Given this list of marker genes ELN, ROCK1, TMOD3, OAZ3, ARF6, WASF1, NCK1, SPTBN2, PIK3R2, CD47, PPM1F, RHOC, FERMT2, ABITRAM, CLASP1, GMFG, EVL, WASHC1, XIRP2, CSF3, PPM1E, SPTAN1, DSTN, MTSS1, RHPN2P1, ASAP3, CYRIB, PFN1, ITGB1BP1, CYFIP2, DNAI3, CCR7, KIRREL1, AVIL, ROCK2, TTC8, LMOD3, SWAP70, BAG4, WASF3, SLIT2, MAGEL2, RHPN2, S100A10, CARMIL2, INPP5K, CDC42EP3, C9orf72, ARHGEF18, CAPZA3, ARHGEF10L, PHLDB2, TESK1, NCKAP1, SHANK1, ARHGAP35, SPTA1, HAX1, LIMK1, ARHGEF5, PFN2, CORO1B, LMOD2, PAK3, PTGER4, RGCC, DLG1 (discs large MAGUK scaffold protein 1), TAC1, MLST8, TRIM27, WASF2, SVIL, PYCARD, PLEKHH2, PRKN, RASA1, CDC42, ALMS1, ADD2, NF2, FLII, PIK3R1, SERPINF2, VASP, BRAF, DMTN, GMFB, CARMIL3, SEMA5A, CCL24, MTPN, NAA80, CCL11, PICK1, BBS4, CFL1, SNX9, WASHC2A, CDC42EP2, TGFB3, CORO2B, WASH6P, CRACD, GSN, NPHS1, BAIAP2, WASHC3, FLNA, KANK2, F2RL1, CTTN, ADD1, MIR20A, TMOD1, TWF2 (NCBI Gene Id 11344), AP1AR, HCK, TACSTD2, WASHC2C, CAPZB, MTOR (NCBI Gene Id 2476), CTNNA2, SMAD3, VIL1, INPPL1, SPTBN5, SH3BP1, MKKS, RGS4, MET, SYNPO (synaptopodin), BAIAP2L2, TWF1, TPM1 (NCBI Gene Id 7168), SSH2, TMOD2, PAK2, ABI2, CCL26, CYRIA, ARHGEF10, ASB2, CLASP2, PDXP, BIN1, AMOT, CCL21, ALOX15, MIR21, HIP1R, KANK3 (KN motif and ankyrin repeat domains 3), FCHSD1, TMSB4X, ARPC5L (actin related protein 2/3 complex subunit 5 like), ACTN2, WAS, FER, ESAM, CFL2, ARPC3, CCDC88A, F11R, SLC9A1, LATS1, CGNL1, ARHGAP6, STMN1, LMOD1, SPTBN1, GPR65, CYFIP1, FHOD1, SCIN, CARMIL1, COTL1, WDR1, ACTG1, SSH1, ARHGEF15, LIMCH1, NRP1, SSH3, ARFGEF1, NCKAP1L, KANK1, SORBS3, WASHC4, SPECC1L, ARAP1, ARF1, VILL, TGFBR1 (transforming growth factor beta receptor 1), TENM1, SYNPO2, RICTOR, EPHA1, PXN, RNH1, TMEFF2, SHANK3, MIR149, MYOC, PREX1, NCK2, CDC42EP4, RAPGEF3, TSC1, RDX, MIR214 (NCBI Gene Id 406996), FRMD7, FCHSD2, CAPZA1, SPTB, LIMA1, APOA1, WNT4 (Wnt family member 4), ARFIP2, CXCL12, TACR1, RAC1, WHAMM, SFRP1, KANK4, BAIAP2L1, GBA2, TMSB4Y, ARPIN, TRIOBP, ABL1, ARHGAP18, S1PR1, DLC1, CORO1A, PTK2B, CDC42EP1, ADD3, DAAM2, ARHGAP28, CAPG (capping actin protein, gelsolin like), RHOA, CAPZA2, ARPC5, SYNPO2L, LPAR1, MIR138-1, WASH3P, MYADM, PPFIA1, CDC42EP5, PLEKHG2, TJP1, RHPN1, GRB2, C15orf62, HCLS1, WASHC5, SPTBN4, EPS8, PRKCE, ARHGAP40, BRK1, PRKCD, CX3CL1, PIK3CA, PLEK, CCN2, SDC4, ARPC2, TMOD4 (tropomodulin 4), PFN3, PAK1, ARFIP1, here is a description of the gene set: studied in species Homo sapiens Human Gene Set: GOBP_REGULATION_OF_ACTIN_FILAMENT_ORGANIZATION Any process that modulates the frequency, rate or extent of actin filament organization.